Given this list of marker genes Flot2, Rnf13, Sec14l3 (SEC14-like lipid binding 3), Alyreffm10, Gm15816, Gstz1, Zbtb45, Klf3, Arid1a, Myadm, Eif4ebp2, Gap43, Plxna2, Trim23, Carmil1, Prxl2a, 4921536K21Rik, Ncs1, Gcnt1, Tenm2, Tpst2, Ctr9 (NCBI Gene Id 22083), Alyreffm13, Prickle2, Rab5b, Pth, Alyreffm17, Ark2c, Hyls1, Anks1, Nt5dc3, Rab14, Hsh2d, Ctbs, Adgrb1, Pak2, Prkar2b, Sox6, Cd200l1, Cnot2, Fbxl17, Dapp1 (NCBI Gene Id 26377), Nid1, Zdhhc9, Atf6b, Blmh, Cd86, Gsx1, Hoxb9, Pcnp, AW554918 (expressed sequence AW554918), Synj2bp, Vegfa, Nr1d1, Dcaf8l, Rgs5, St6galnac3, Ost4, 0610030E20Rik, Anxa2, Tmem79, Prr3 (NCBI Gene Id 75210), Dgkk, B4galt1, Zfp950, Klhl29, Rgs7bp, Ckmt2, Coro1c, Ifi213, Ldlrad3, Plagl1, Eif4b, Ptbp2, Snx27, Fchsd2, Nmnat2, Zfp169, Alyreffm16, Tmem141 (transmembrane protein 141), Baz2a, Alyreffm11, Phactr2, Zfp385a, Col11a1, Ptpn14, Ctnnd1, Cdc27 (cell division cycle 27), Tnip3, Clvs1, Wdtc1, Exd2, Specc1, Sv2c, Igf1r, Alyreffm14, Xkr4, Socs3, Dpysl5, Alyreffm15, Zmym3, Fam222b, Slc16a14, Thra, Tfcp2l1, Bsn, Phlpp2, Luzp1, Srcap, Igf1, Usp17la, Hook3, Ppp6r1, Fignl2, Tspan18, here is a description of the gene set: Mouse Gene Set: MIR_7012_5P Genes predicted to be targets of miRBase v22 microRNA mmu_miR_7012_5p in miRDB v6.0 with MirTarget v4 prediction scores > 80 (high confidence targets). species: Mus musculus from publication Chen Y, Wang X (PMID 31504780)